The following is a description of a gene set: species: Homo sapiens Human Gene Set: EPPERT_PROGENITOR Xenograft studies indicate that some solid tumors and leukemias are organized as cellular hierarchies sustained by cancer stem cells (CSCs). Despite the promise of the CSC model, its relevance in humans remains uncertain. Here we show that acute myeloid leukemia (AML) follows a CSC model on the basis of sorting multiple populations from each of 16 primary human AML samples and identifying which contain leukemia stem cells (LSCs) using a sensitive xenograft assay. Analysis of gene expression from all functionally validated populations yielded an LSC-specific signature. Similarly, a hematopoietic stem cell (HSC) gene signature was established. Bioinformatic analysis identified a core transcriptional program shared by LSCs and HSCs, revealing the molecular machinery underlying stemness properties. Both stem cell programs were highly significant independent predictors of patient survival and were found in existing prognostic signatures. Thus, determinants of stemness influence the clinical outcome of AML, establishing that LSCs are clinically relevant and not artifacts of xenotransplantation. Genes up-regulated in human hematopoietic lineage committed progenitor cells versus hematopoietic stem cells (HSC) and mature cells. from publication Eppert K, Takenaka K, Lechman ER, Waldron L, Nilsson B, van Galen P, Metzeler KH, Poeppl A, Ling V, Beyene J, Canty AJ, Danska JS, Bohlander SK, Buske C, Minden MD, Golub TR, Jurisica I, Ebert BL, Dick JE (PMID 21873988), and this is the list of marker genes: ADGRA3, FBXO7, XK, RFX7, LRRFIP2 (LRR binding FLII interacting protein 2), TIPIN, PLIN2, HS2ST1, CENPU, MACIR, RYR3, FANCI, MTREX, PSMD1, DNAJC6, BAMBI, PCTP, CALU, SLF1, MRPL35, POMK, LDHB, RFC3, TRIP13, LRPPRC, PRKAR2B (protein kinase cAMP-dependent type II regulatory subunit beta), IDE, WASF1, PRKDC, TMOD3, DLC1, MRE11, MTHFD2, ACO1, AHCYL1, FECH, TPR, GINS2, PAICS, DUT, ARMC8, HDC (histidine decarboxylase), EIF5B, NDC1, TAL1, PCLAF, MEX3B, HNRNPR, PHF6, ASRGL1, ACSM3, SCD, UMPS, STEAP3, CCNJ, LANCL2, ANK1, PALM2AKAP2, TPM1, CTPS1, MARCHF5, TRIT1, PMP22, FKBP14, NDC80, CDK7, NCBP1 (nuclear cap binding protein subunit 1), POLE2, DDAH1 (dimethylarginine dimethylaminohydrolase 1), ZWINT, CCNB2, BMS1, HBS1L, PDLIM1, SORD, MINPP1, MSH3, ANKRD27, NET1, PLK4, EIF2S1, ZNF225, MICAL2, DTL, EIF2AK1, TNIK, SLC27A2, HAUS6, PEX5, KNTC1, KIFAP3, WRN, RRM1, SPTA1, CHEK2, CSNK2A1, CTNNBL1, SMC1A, P2RY1, IPO5, UBE2FP1, MTMR2, ODC1, CNRIP1, HMGXB4, STAM, DCAF7, LHFPL2, RACGAP1, HIRA, METAP2, RHAG, MYCN, HSP90AA1, MIPEP, TMEM97, DLAT, PDZD8, NOMO1, CHEK1, CKAP5, FAM171A1, METTL14, BTK, IDH3A, HMGB1, POLA1, TFRC, MTPAP, SUPT16H, KCNQ5, SSX2IP, TXNRD1, CDK6, SART3, RMDN1, TM9SF3, EREG